The following is a description of a gene set: Any process that stops, prevents or reduces the frequency, rate or extent of CD4-positive, alpha-beta T cell proliferation. Human Gene Set: GOBP_NEGATIVE_REGULATION_OF_CD4_POSITIVE_ALPHA_BETA_T_CELL_PROLIFERATION species: Homo sapiens, and this is the list of marker genes: LGALS9C, CD274, VSIR, XCL1 (NCBI Gene Id 92337), LGALS9, NDFIP1, LGALS9B, CBLB, TWSG1, FOXP3, ITCH, ARG2